Given this list of marker genes SMC3, NBN, RAD21, BRCA1, RAD50, PAXIP1, SMC1A, RAD18, ATM (ATM serine/threonine kinase), MDC1, MRE11, here is a description of the gene set: Human Gene Set: WP_SMC1SMC3_ROLE_IN_DNA_DAMAGE_CORNELIA_DE_LANGE_SYNDROME SMC1/SMC3 role in DNA damage - Cornelia de Lange Syndrome species: Homo sapiens